Given this list of marker genes Ubb, Ep300 (NCBI Gene Id 328572), Sqstm1, Psmb4, Cox6a2, Psmc3, Ndufa4, Cox7a1, Cycs, Cox4i1, Gpx1, Map1lc3b, Gpx6, Rps27a, Nudt2, Psma6, Cox6c, Psmd6, Psmd13, Cul1, Sin3a, Ncor2, Ncf1, Gpx8, Cox6a1, Psmc1, Gpx3, Ero1a, Mul1, Psmc2, Alb, Mafk, Cox4i2, Psmb5, Hbb-bt, P4hb, Prdx3, Ncoa1, Prdx5, Psmc5, Txnrd2, Psmd1, Prdx1, Tbl1x, Gstp1, Ncf2, Higd1c, Psmb6, Psmc6, Txn1, Psmd7, Sod3, Ccs, Hmox2, Vcp, Hdac3, Psmb7, Psma4, Psma1, Blvrb, Carm1, Med1, Psma7, Psma5, Ufd1, Sesn2, Cox7c, Gpx7, Psmc4, Gpx2, Cox5a (cytochrome c oxidase subunit 5A), Cox7a2l, Cox8a, Psma2, Sod2 (NCBI Gene Id 20656), Psmd12, Nox4, Helz2, Cox8c, Psma3, Txnrd1, Cyba, here is a description of the gene set: Reactome Pathway: Cellular response to chemical stress This event has been computationally inferred from an event that has been demonstrated in another species.<p>The inference is based on the homology mapping from PANTHER. Briefly, reactions for which all involved PhysicalEntities (in input, output and catalyst) have a mapped orthologue/paralogue (for complexes at least 75% of components must have a mapping) are inferred to the other species. part of: Cellular responses to stress electronically inferred by orthology from the curated human pathway studied in species Mus musculus